Given this list of marker genes ABHD12B, PLAAT5, LIPN, CCL5, PLA2G4B, PDPK1, PLA2G2A, FAM83B, DDHD1, PNPLA6, SMPD3, PLCG1, CEL, PLD1, APOC1, BDKRB2, PLD2, PGAP6, PLCB4, PLCB2, PLB1, MGLL, CHRM1, GM2A (ganglioside GM2 activator), ANGPTL4, PLCL2, ANXA4, PLCH2, LGALS13, SEC23IP, SMPD4, NCEH1, GDPD3, PLA2G3, CLC, PLD3, ABHD3, ASPG, PDIA3, ANXA2, PLAAT4, ANXA8, PINLYP, PROCA1, CES1, PLA2G4D, LIPK, PITPNM3, CHRM5, PNLIPRP3, AADAC, PLBD1, ARL1, CCR5, LIPI, SCGB1A1, ABHD11, CHRM3, APOC2, DDHD2, NOTUM, LIPH, LIPG, APOA2, PLCE1, ABHD12 (abhydrolase domain containing 12, lysophospholipase), ANXA5, PLCH1 (NCBI Gene Id 23007), LCAT, PLA2G2C, LYPLA2, LIPM, ARHGAP6, PLA2G2F, PNPLA2, DAGLA, GDE1, GDPD1, PLAA, FAF2, LYPLAL1, PLCD4, PLD4, PLA2G4C, ABHD5, PLCD3, LPL, SMPDL3A, ABHD1 (NCBI Gene Id 84696), PNPLA7, PLA2G2E, LCK, ABHD6, APOA5, SNCA, PLCD1, PDGFRA, LYPLA1, STX4, ANGPTL3, LIPC, PLCZ1, PLAAT2, CCL3, FYN, FAAH, EDNRA, LIPA, ABHD16B, PLCB1, PLA2G12A, PLA1A (phospholipase A1 member A), APOH, PLA2R1, PLBD2, ANXA3, DAGLB, PRDX6, PLCG2, CASP3, CCL8, PNPLA4, ABHD4, OC90, GDPD5, PNPLA3, PLA2G12B (NCBI Gene Id 84647), ARF4, ABHD2, PNPLA8, GPLD1, SMPD1, PNPLA5, NAPEPLD, PLA2G4F, SMPDL3B, APOC3, PLCB3, PDC, ANXA2P2, PNLIPRP2, ENPP2, PLA2G4E, PLA2G5, ABHD16A, PLAAT3, PLD6, LDAH, PNPLA1, PDGFRB, PNLIPRP1, F2RL2, PLA2G2D, PLA2G10, CASR, LIPF, BTK, PLCL1, SMPD2, GPIHBP1, CCR1, PLA2G4A, PLA2G6, PLA2G15, PLAAT1, ENPP7 (NCBI Gene Id 339221), SRC, PNLIP, LIPE, ABHD15, SNCB, HRAS, PLA2G7, ANXA1, PLA2G1B, here is a description of the gene set: Human Gene Set: GOMF_LIPASE_ACTIVITY studied in species Homo sapiens Catalysis of the hydrolysis of a lipid.